Given this list of marker genes Acadsb, Acat1, Bckdk, Hsd17b10, Bcat2, Ilvbl, here is a description of the gene set: Mouse Gene Set: GOBP_ISOLEUCINE_METABOLIC_PROCESS The chemical reactions and pathways involving isoleucine, (2R*,3R*)-2-amino-3-methylpentanoic acid. species: Mus musculus